The following is a description of a gene set: studied in species Mus musculus The process in which a relatively unspecialized T cell acquires specialized features of a mature T follicular helper cell. Mouse Gene Set: GOBP_T_FOLLICULAR_HELPER_CELL_DIFFERENTIATION, and this is the list of marker genes: Tbk1, Il6, Foxp1, Rc3h2, Gpr183, Rc3h1, Ascl2, Il21, Pik3r1